The following is a description of a gene set: from publication Toker A, Engelbert D, Garg G, Polansky JK, Floess S, Miyao T, Baron U, Düber S, Geffers R, Giehr P, Schallenberg S, Kretschmer K, Olek S, Walter J, Weiss S, Hori S, Hamann A, Huehn J (PMID 23420886) Human Gene Set: GSE42021_CD24LO_TREG_VS_CD24LO_TCONV_THYMUS_DN We investigated at which stage of maturation commitment to a stable Foxp3-expressing phenotype takes place. We assessed stability of Foxp3 expression in thymic Foxp3+ Treg subsets of different maturity, defined by CD24 expression. Next we compared gene expression profiles of Foxp3+ Treg subsets (+) of different maturity (24lo, 24int, 24hi) and could identify a set of genes that were specifically up or downregulated in Foxp3+ Tregs, but not in Foxp3- conventional T cells, in a maturation-dependent manner. species: Homo sapiens Genes down-regulated in CD42 low cells from thymus: T reg versus T conv., and this is the list of marker genes: ERP29, SRP9, PRPF38A, PKIG, RPL19, PCBD2, SEMA4A, CTSE, BMP5, GTF2F1, MRPS25, ETHE1, MAP4K2, CSNK1G2, RERE, GUK1, FES, RBM42, PSME1, IRGM, GBA2, SEC61B, STOML2, PSEN1, CDC37, SCARB1, ESRRA, NDST2, ADPRM (NCBI Gene Id 56985), VAMP8 (NCBI Gene Id 8673), DYNLL1, NELFE, CIAO1, RPS16, SLC38A10, BCAT2, DFFA, SLC4A8, SNX12, DUS1L, C1QB, PPFIA4, PTCD2, MSH2, EEF1B2, LY86, CDK5, RACK1, AKT1, ING4, SELENOH, ACVRL1, PRPF6, SDHB, GOLGA3, CAPNS1, DDX39B, TIMM8B, TTC14, NDUFA8, SEC61A1, AURKAIP1, RSRP1, CD93, ATP5PO, BAK1, RPUSD4, TYSND1, U2AF1L4, MBD3, TNFSF10, TYMP, MRPS12, MAPK3, RAD50, ADAM28, RPS5, NBR1, TBC1D22A, DAP, ARHGAP45, COL13A1, RAD1, HSP90B1, YIF1A, GTF2H4, RING1, RCAN3, RNASEH2A, PSMB6, MRPL20, SNRPD2, FLCN, LMAN2, MAPK10 (mitogen-activated protein kinase 10, NCBI Gene Id 5602), VPS72, NCBP2AS2, PDHA1, EIF3K, DCTN3, GDF3, RAB8A, RPL3, REEP5, GRN, NAA38, RBCK1, CYBA, ATP6V0E1, NSUN2 (NOP2/Sun RNA methyltransferase 2), CLTA, TPI1, AMBP, NPEPL1, MAN2B1, PEX19, PPIB, PNPLA2 (patatin like phospholipase domain containing 2), XRCC1, EIF3L, TRPC5, F8A1 (NCBI Gene Id 8263), ACTL6B, PNKP, MAST3, COX7A2, NUP85, PIGX, HLA-DMA, SAP30 (NCBI Gene Id 8819), PRPF31 (NCBI Gene Id 6106), HSF1, PCNT, ECHS1, MIPOL1, ARHGDIA, COLGALT1 (collagen beta(1-O)galactosyltransferase 1), NUBP1, MAF1, SEMA6B, SUPT4H1 (SPT4 homolog, DSIF elongation factor subunit), WWP2, ARPC1A, CHCHD7, MRAS, ENO1, STAT5B, PRKCD, CIAO2B, TLE5, ARL10, GNAS, FKBP8, ENO3, MFSD5, RPL28, MEA1, ALDH3A2 (aldehyde dehydrogenase 3 family member A2), ANAPC11, MKNK2, PREPL (prolyl endopeptidase like), SMARCB1, PTPN18, TALDO1, JMJD8, RPP25L, MRPL34, NAXE, STRN4, INTS3 (NCBI Gene Id 65123), MXD4 (MAX dimerization protein 4), SCAF8, ZFYVE19 (zinc finger FYVE-type containing 19), PRKCSH, PROM1, TMEM259, TXNIP, ULK1 (unc-51 like autophagy activating kinase 1), TMEM179B, TFIP11, PPP1R21, SESN1, CTSA, NDUFS3, ZNF808, CSK, COMMD2, UBALD2 (NCBI Gene Id 283991), CLPP, PSMD3, IL18, URM1 (NCBI Gene Id 81605), UQCRC1, RASD1, TOR1B, LMF1, RGL2, LYPLA2, SCEL, SDHC